Given this list of marker genes WDR7, SNTN, LILRB3, ZNF148, ATG7, C2CD6, MRPL11 (NCBI Gene Id 65003), WDR43, GPR176, RAD51B, PARD6B (NCBI Gene Id 84612), SORCS3 (sortilin related VPS10 domain containing receptor 3), NOTUM, CYP2C8, DENND5B, POTEF (POTE ankyrin domain family member F), FAR1, NET1 (neuroepithelial cell transforming 1), CREM, UBR3, SAE1 (SUMO1 activating enzyme subunit 1), SMN2, AZIN1, PRSS23, POTEM, R3HDM1, HOXA13, NAA35, MEX3C, SNX13, DLEU7, NDUFC2, PAFAH2, IFT74, FUBP1, TMCC3, HIPK3, FCGR3A, NFYB, ROPN1B, CROT, FCGR3B, MFN1, TRIM8, BTRC, KLHL29, KGD4, SLC25A46, ATP1B4, GABARAPL2, NFAT5, CDC5L, MOSPD1, IDE, ZFP82, ZFC3H1, SMN1, LYZ, PNKD, HOXC5, ARMC10, UCP3, PDIA5, TMEM47, PRRX1, WDSUB1, TLCD4, JAKMIP2, TMEM68, OPA1 (NCBI Gene Id 4976), INPP4B (inositol polyphosphate-4-phosphatase type II B), CPED1, ENSG00000187185, CSRNP3, HELQ, AHCYL1, DZIP1, CAMTA1, PDE12, DDX46, GABRR2, RAP1GDS1, ERLIN2, FAM220A, DUOX2, SEPSECS, METAP1, TRIM55, CAPRIN1, AP1AR, ALG2, ANKRA2, NSUN6, SCML1, NOVA1, G2E3, ALG10B, MID1IP1, MCOLN2, UTP14C, ARL14, LCT, here is a description of the gene set: studied in species Homo sapiens Human Gene Set: MIR382_3P Genes predicted to be targets of miRBase v22 microRNA hsa-miR-382-3p in miRDB v6.0 with MirTarget v4 prediction scores > 80 (high confidence targets). from publication Chen Y, Wang X (PMID 31504780)